The following is a description of a gene set: Reactome Pathway: MHC class II antigen presentation part of: Adaptive Immune System studied in species Mus musculus electronically inferred by orthology from the curated human pathway This event has been computationally inferred from an event that has been demonstrated in another species.<p>The inference is based on the homology mapping from PANTHER. Briefly, reactions for which all involved PhysicalEntities (in input, output and catalyst) have a mapped orthologue/paralogue (for complexes at least 75% of components must have a mapping) are inferred to the other species., and this is the list of marker genes: Kif2c, Racgap1, Ctsd, Tuba8, Sec24b, Sec24d, Kif3c, Kif26a, Osbpl1a, Tubal3, H2-Oa, Ctsh, Ap1s1, Dynll1, Lag3, Kif20a (NCBI Gene Id 19348), Ctsf, Sec31a, Cenpe, Sptbn2, Tubb6, Dctn1, Tuba1c, Lgmn, Tuba4a, Ap2m1, Arf1, Kifap3, Rab7, Sec24a, Ifi30, Dync1li2, Ap1m1, Klc3, Tuba1b, Ap2s1 (NCBI Gene Id 232910), Tuba3b, Actr1a, Ctsc, Tubb2b (NCBI Gene Id 73710), Ap2a1, Tubb4b, Klc4, H2-Ob, Ap1b1, Kif2b, Ap2b1, Dctn6, Tuba1a, Dnm2, Tubb4a, Kif5b, Ctss (cathepsin S), Cd74 (CD74 antigen (invariant polypeptide of major histocompatibility complex, class II antigen-associated)), Ap1s3, Actr10